The following is a description of a gene set: A process in which RNA is transported to, or maintained in, a specific location. Mouse Gene Set: GOBP_RNA_LOCALIZATION studied in species Mus musculus, and this is the list of marker genes: Alyreffm8, Nup62 (NCBI Gene Id 52394), Nrde2, Alyreffm6, Sec13, Ncbp1, Xpo1, Senp2, Rftn2, Tomm20, Zfp385a, Qki, Rftn1, Alyreffm11, Nxf2, Pom121, Nxf3, A1cf, Seh1l, Pum2, Alyreffm7, Alyreffm3, Srsf7, Tgfbr2, Poldip3, Magoh, Wrap53, Ddx25, Akap8l, Nup85, Ran, Nop58, Rbm8a, Srsf1, Parp11, Pnpt1, Alyref2, Hnrnpa1, Zc3h11a, Tnks, Sidt1, Nup133, Nxt1, Hnrnpu, Znhit3, Bicd2, Zc3h3, Thoc2l, Dhx9, Nup54, 1700017N19Rik, Ncbp2, Nol6, Stau1, Pabpn1, Nup58, Pih1d1, Xpot, Atr, Fubp3, Pom121l2, Fmr1, Iws1, Hhex, Nxf1, Kpnb1, Thoc6, Terf1, Nup160, Cct2, Tomm20l, Cpsf6, Fxr1, Supt6, Htt, Lrpprc, Nup50, Eny2, Chtop, Alkbh5, Nup98, Gle1, Ythdc1, Nup37, Slbp, Nup153, Thoc7, Snupn, Cct4, Ddx19a, Magohb, Dkc1, Hsf1, Ddx39a, Igf2bp3 (insulin-like growth factor 2 mRNA binding protein 3), Eif4e, Nup93, Nsun2, Nup88, Rae1, Cetn2, Alyreffm1, Flot1 (NCBI Gene Id 14251), Sem1, Khsrp, Kif5c, Znhit6, Nup35 (nucleoporin 35), Thoc5, Zfp36, Nup188, Cetn3, Ncbp3, Alyreffm10, Sarnp, Thoc3, Khdrbs1, Hnrnpa3, Exosc10, Nup214, Casc3, Alyreffm14, Ranbp17 (RAN binding protein 17), Eif4a3 (NCBI Gene Id 76481), Ybx1, Fbl, Alyreffm9, Setd2, Nup210, Hnrnpa2b1, Nup107, G3bp2, Ddx39b, Arc, Pcid2, Tpr, Alyreffm2, Atm, Ckap5, Nxt2, Mrpl18, Igf2bp1, Thoc1, Caprin1, Zfp36l1, Yy1, Phax, Tst, Nup62cl, Mapt, Ssb, Wnk1, Rbm33, Ndc1, Prpf6, Ranbp2, Cpeb1, Nutf2, Rbm15b, Parn, Stau2, Mcm3ap, Nup42, Ahctf1, Peg10, Srsf3, Nup155, Aaas, Alyreffm5, Alyreffm4 (NCBI Gene Id 100043224), Fxr2, Dhx36 (DEAH-box helicase 36), Sidt2, Nup43, Nxf7, Ddx19b, Igf2bp2, Alyref, Tcp1, Thoc2, Xpo5, Hnrnpab, Dcp2, Fyttd1